Given this list of marker genes Pde4c, Pde10a, Pde7a, Pde8b, Pde4d, Pde8a, Pde7b, Pde4a, here is a description of the gene set: The chemical reactions and pathways resulting in the breakdown of the nucleotide cAMP (cyclic AMP, adenosine 3',5'-cyclophosphate). studied in species Mus musculus Mouse Gene Set: GOBP_CAMP_CATABOLIC_PROCESS